The following is a description of a gene set: species: Homo sapiens Gastrin-CREB signalling pathway via PKC and MAPK Human Gene Set: REACTOME_GASTRIN_CREB_SIGNALLING_PATHWAY_VIA_PKC_AND_MAPK, and this is the list of marker genes: CREB1, GRB2, CCKBR, MMP3, PRKCA, GAST, MAPK1, RPS6KA3, HBEGF, HRAS, MAPK3, NRAS (NCBI Gene Id 4893), SOS1, RPS6KA1, MAPK7, EGFR, KRAS, RPS6KA2